Given this list of marker genes Igf1, Rab44, Usp19, Fdx1, Slc8a3, Ide, Ifnk, Fpr2, Hnf1a, Nucks1, Stub1, Ces1d, Prkci, P2rx1, Ptpre, Mecp2, Mbd5, Sdc1, Foxred2, Erbb4, Flna, Tmem38a, Oxt, Ifna14, Ddi2, Slc2a8, Hcfc2, Uprt, P2rx6, Get4, Ly6e, Tnfsf10, Ucp2, Pklr, Bcl2l2, Ncstn, Gabra1, Mir376c, Otop1, Klhl22, Mat2a, Map3k5, P2ry6, Prkcb, Serpina1d, Ankzf1, Txn1, Hdac5, Esrra, Sos1, Nr4a2, Fpr-rs4, Npr2, Oprk1, Fpr-rs7, Mrgpra3, Riok3, Ifna9, Tlr4, Nr4a3, Sec61bl, Chuk, Chmp5, Arhgef2, Apoe, Cd36, Ramp3, Fancb, Fbxo17, Ghr, Sp1, Apc, Orai1, Ehmt2, Prnp, Prss2, Blm, Creb1, Nherf1, Sco1, Htt, Ntrk3, Erlin2, Aplp1, Star, Mir382, Mexis, Gna14, Pcsk1, Pde3b, Ptk2 (PTK2 protein tyrosine kinase 2), Serpina3g, Flt3, Leprot, Selenon, Insig1, Rnf185, Chrng, Irs4, Ncoa2, Ifna6, Slco1b2, Pdk2, Glp2r, Casp7, En1, Obp2a, Stat2, Fgfr3, Usp25, Rps6kb1, Scnn1g, Il1b, Slc5a5, Oprd1, Adamts13, Ncoa5, Braf, Defb25, Ppp2r2a, Gabrb3, Uchl3, Tomm70a, Foxc2, Ube3a, Rangap1, Flot1, Edem1, Adipor2, Crtc3, Pld2, Bace1, A1bg, Calcr, Rplp0 (ribosomal protein lateral stalk subunit P0), Gfral, Panx1, Stt3b, Camk2a, Ces1h, Mup1, Cbs, Ctnnb1, Appl1, Nod2, Parp1, Colec12, Akt3, Zbed3 (NCBI Gene Id 72114), Tns2, Axl, Gcg, Gnao1, Pax4, Htr1a, Ccr7, Gsk3b, Pik3cg, Tmem67, Usp13, Gstm3, Klf16, Ctsk, Cacna1a, Hdac9, Mas1, Dhx15, Hrh4, Slc1a1, Epha8, Prmt5, Prkca, Chrm5, Ezh2, Lyn, Gpx1, Prkcq, Ly6g6e, Ppp3ca, Eef2k, Arc, Pik3r1, Tgfb1, Ly6g, Mir3072, Enpp1, Sox17, Tmem129, Epha2, Myd88, Pak1, Dmtn, Hnrnpd, Srsf5, Cflar, Hcn1, Gnas, Prkcz, Htr4, Adra1b, Mir376b, Gpld1, Epha7, Gjb2, Man1b1, Igfbp5, Insig2, Chrna2, Mef2c, Gm13276, Ptpn22, Mapk8, Slc27a4, Pkd2, Sdf2l1, Hhex, Ciita, Ins2, Nfkb1, Ceacam1, Trim25, Prkn (NCBI Gene Id 50873), Nppc, Kdm1a, Serpina3k, Smpd1, Duox1, Grk2, Cyp11b2, Tmem259, Musk, Tgm2, Ywhag, Adra2a, Fcer1g, Slc7a5, Pdcd4, Cdk2, Hsp90b1, Gnrhr, Trpc3, Kcnb1, Bcar1, Mir369, Cav2, Ccna2, Rab10, Fut7, Homer2, Jak2, Large1, Ubqln1, Rapgef3, Nr1h4, Nck1, Otc, Hadh, Ces1f, Acvr1c, Ly6a (lymphocyte antigen 6 family member A), Prkd1, Ubr2, Afg3l2, Akap6, Ceacam2, Cacybp, Gpihbp1, Jup, Rnls, Aqp8, Cyfip1, Cat, Mir494, Eif2b1, Serpina3i, Mavs, Chrnd, Ces1g, Trem2, Ogg1, Mir27a, Hspa5, Erlin1, Eif2b2, Sik2, Icam1, Rftn1, Nono, Inpp5k, Npm1, Dntt, Hras, Actb, Bdnf, Peli1, Chrna6, App, Sorl1, Ccl19-ps3, Klf15, Mir544, Ptpn2, Derl1, Ntrk1, Ccl19-ps6, Stc1, Snx5, Npc1, Lrp6, Ahcyl1, Asph, Kl, Rela, Tek, Tie1, Larp1, Trdmt1, Stxbp3, Tyms, Diaph1, Fgfr2, Adipor1, Brsk2, Pou4f2, Ddi1, Irs1, Zdhhc7, Grin2a, Fcgr2b, Pde4d, Faf1, Rgs8, Gpd1, Cd9, Ubxn6, Ryr2, Slc26a3 (NCBI Gene Id 80590), Slc24a4, Tomm20, Rgs4, Ephb4, Sdk1, Ror2, Bcl2l1, Insrr, Grb14 (growth factor receptor bound protein 14), Chrm2, Fosl2, Rpl23, Gpr173, Agt, Prkcg, Gnai2, Afg3l1, Rap1b, Ass1, Slc6a3, Ccnd3, Leprotl1, Card9, Gata5, Sin3a, Bmt2, Kcnq1, Srd5a2, Cacna1b, Usp14, Irs3, Slc6a1, Bmp7, Agtr2, Tgfbr3, Igf2, Gnaq, Mfn2, Egfr, Mir409, Myrf, Gabrb2, Ppara (peroxisome proliferator activated receptor alpha), Slurp2, Adtrp, Golph3, Mir487b (NCBI Gene Id 723940), Ly6g2, Lonp1, Ghsr, Crhr1, Dpep1, Map2k1, Gpt, Sorbs2, Fer, Zbtb7b, Slit2, Slc25a33, Nqo1 (NCBI Gene Id 18104), Gnal (NCBI Gene Id 72463), Agrp, Atp2b1, Kcne1, Mir154, Col6a1, H2az1, Lep, Chrna1, Ep300, Epha1, Top2b, Hnmt, Ltk, Crls1 (NCBI Gene Id 75371), Cacng4, Marchf6, Irak3, Flt1, Timp1, Epha5 (NCBI Gene Id 13839), Irf1, Dnajb2, Scnn1b, Trim72, Map3k7, Gldc, Rps6-ps4, Sting1, Mapk1, Ndufs4, Cdk5, Ephb2, Klf2, Eif2ak3, Stxbp4, Tlr9, Capn10, Nos1, Srsf6, Adrm1, Mst1r, Dhfr, Per1, Casq2, Apoc3, Pqbp1, Mylip, Atp2a1, Sirt1, Hlcs, Ppp5c, Cnga3, Mir301, Gad2, Mir423, Drd2, Usf1, Prkaa1, Rnf139, Gck, P2rx3, Umod, Erfe, Insr, Igfbp1, Ifna15, Crtc2, Bglap2, Bglap3, Brip1, Prkaa2 (protein kinase, AMP-activated, alpha 2 catalytic subunit), Hdac2, Ces1e, Ereg, Srsf3, Serpina3c, Afg2b, Retn, Gmps, Ifna7, Htr1b, Bag6, Ubxn2a, Inppl1, Gata6, Syk, Slc39a14, Eif2b5, Gm13272, Sesn2, Ly6h, Aldob, Jak1, Iqgap1, Inava, Ube2j1, Cry1, Akt1, Hadha, Rcn3, Fbxo27, Egln1, Serpina1c, Lrrk2, Carm1, Sgk1, Ces1b, Serpina3h, Uros, Blvra, Psen1, Slc8a1, Lpin3, Nploc4, Dgkq, Trib3, H13, Sel1l2 (NCBI Gene Id 228684), Cdk5r1, Arpc2, Hmgcs1, Cd68, Ly6m, Ngfr, Fbn1, Smpd3, Ubxn10 (UBX domain protein 10), Ifnb1, Mstn, Nt5e, Stat5b, Cyp27b1, Pdk4, Kank1, Foxp3, Trex1, Ptprf, Pmaip1, Prkar1a, Ggh, Six1, Btg1, Uqcrc1, Man1c1, Mtcl2, Selenos, Syvn1, Rhbdd1, Lta4h, Ptpra, Reg3g, Rps6, Gabrg2, Met, Cited1, Htr7, Pitx3, Lrp1 (NCBI Gene Id 16971), Zfp592, Ctsd, Akr1c18, Bsg, Sts, Cyp11b1, Pfkfb1, Rragd, Cad, Daxx, Tmx1, Rab31, Rnf4, Calr (NCBI Gene Id 12317), Mir543, Adcy5, Nfkbiz, Borcs7, Rhoq, Capn1, Fbxo44, Mapk3, Crkl, Nfe2l2, Oxtr, Amfr, Ucp3, Cacna2d1, Col1a1, Trim24, Abat, Mzb1, Grin1, Wdtc1, Stat1, Serpina1e, Eif4ebp2, Canx (NCBI Gene Id 66219), Socs3, Nr5a1, Ptprj, Fgfr1, Tmem38b, Cyc1, Rapgef2, Ntrk2 (neurotrophic tyrosine kinase, receptor, type 2), Nkx6-1, Ifnz, Reg3b, Ces1c, Ly6f, Ubac2, Pld1, Brca1, Adora2a (adenosine A2a receptor), Baiap2, Thbd, Gm13283, Itgb1, Abcc9, Sort1, Rbp4 (retinol binding protein 4, plasma), Ezr, Ifna5, Srebf2, Adm, Serpina1b, Xbp1, Itpr2, Irak1, Raet1d, Rigi, Mmp9, Rnft2, Gna15, Alad, Lgmn, Crhbp, Trarg1, Castor2, Ace, Epha6, Fam114a1, Scn11a, Pde1b, Casr (NCBI Gene Id 12374), Inhbb, Adrb2, Hnf4a, Chek1, P2ry12, Pdpk1, Zcchc3, Ubqln2, Htr6, Fbxw8, Ubxn1, Raf1, Mtor, Ufl1, Foxo1, Slc6a4, Dlg4, Ldlr, Mul1, Ly6g6d, Duox2, Anxa7, Fpr-rs6, Itpr3, Zfp36l1, Cpt1a, Ddr1, Appl2, Ncam1, Slc2a1, Ppp1r9b, Vps13c, Klf4, Nefl, Serpina1a, Sesn3, Drd4, Tnfsf4, Eif6, Prkcd, Comt, Itga2, Trpv4, Bloc1s6, Bglap, Stambpl1, Grb7, Adcy6, Ern1, Pip4k2b, Kit, Lhcgr, Mmp19, Hcn3, Ticam1 (NCBI Gene Id 224899), Faf2, Mrgpra1, Ctnna1, Galp, Rab8a, Prmt1 (protein arginine N-methyltransferase 1, NCBI Gene Id 80681), Smarcc1, Hdac6, Plcd1, Htr2b, Mapk14, Cxcl2, Rftn2, Src, Aup1, Svip, Sp7, Dhx36, Nanog, Ada, Dnajb12, Ghrhr, Tnf, Itga4, Cib2, Fkbp1a, Scnn1a, Pparg, Lars1, Chrm4, Map1b, Epha10, Gm13271, Akap7, Prkaca, Kcnc1, Lpin2, C5ar1, Gstm6, Cdh13, Rapgef1, Nlrp1a, Stk11, Ache, Hcn2, Spidr (NCBI Gene Id 77584), Bcar3, Eprs1, Cela2a, Ccdc47, Drd3, Dbh, Derl3, Osbpl8, Hes1, Slc1a2, Tmub1, Fbp1, Mia3, Mtarc2, Cdo1, Gm13275, Kbtbd2, Ifna2, Hnrnpk, Tyro3, Ephb3, Fbxo6, Rad51 (RAD51 recombinase), Chrnb4, Tlr2, Ankrd26, Tuba1a, Slc2a4, Epm2aip1, Gper1, Ces1a, Epha3, Slc26a6, Gata1, Mir143, Flt4, Th, Il10 (interleukin 10), Pde12, Sox9, Irs2, Ptger1, Mir667, Tdo2 (tryptophan 2,3-dioxygenase), Rbm4, Dhx9, Cnr1, Tshr, Alk, Ranbp2, Sesn1, Max, Fos, Gm13277, Lrrc25, Blvrb, Atp1a3, Phb1, Khk, Sec61b, Cul3, Clgn, Ikbkb, Cracr2a, Erbb2, Kat7, Fcsk, Cps1, Grm2, Gdf15, Gh, Adgrl3, Drd5 (NCBI Gene Id 13492), Ripk2, Mup3, Tpr, Adcy8, Ren1, Grb10, Nfkbia, Epha4, Birc2, Mapkap1, Psmc6, Aqp11, Eif2a, Grb2, Pdgfrb, Ncl, Gria2, Htr2a, Ifna4, P2rx5, Ifna13 (interferon alpha 13), Alpl, Stat3, Hsf1, Slc9a1, Xlr4b, Ager, Epg5, Crem, Socs2, Pid1 (NCBI Gene Id 98496), Gstp1, Tor1a, Echdc3, Cdkn1b, Ddx21, Umodl1, Ccl19-ps4, Grxcr1, Ptprv, Palm, Nr3c2, Sfrp1, Hdac8, Ros1, Plcg2, Recql5, Lncbate10, Lypd1, Edem3, Ifih1, Rap1gds1, Rap1a, Atrx, Atxn3, C1qtnf12, Vim, Casp1 (NCBI Gene Id 12362), Hmga1, Lpl, Nsmce3, Tbc1d4, Gna11 (guanine nucleotide binding protein, alpha 11), Rnf103 (ring finger protein 103), Tsc2, Jag1, Fgfr4, Smad3, Pde2a, Setd2, Ptgs2, Pnpt1, Cacna1s, Lipa, Gclc, Cybb, Pik3ca, Trp53, Gnb5, Errfi1, Ssh1, Hcn4, Chrna7, F7, Fadd (Fas associated via death domain), Eif2b3, Trpc1, Nagk, Gucy1b1, Cdk1, Akap9, Bche, Eif2s1, Trpm2, Ly6c2, Ryr1, Lmnb1, Edn1, Pcna, Gja1, Plcb1, Reg1, Ubxn8, Dnajb9, Agap2, Srebf1, Gdf10, Ifnab, Tlr6, Cntnap2, Rock1, Pomc, Snx6, Mir23a, Ccl19, Rb1, Mir150, Ptk2b, Nlrp3, Kcnj8, Gstm7, Dnai1, Lpin1, Nscme3l, Cgas, Abcc1 (NCBI Gene Id 94110), Ins1, Mir539, Mir124a-1hg, Atp2b4, Slc30a10, Myo5a, Itgb2, Ddx1, Got1, Edem2, Eif4ebp1, Rgs10, Erlec1, Dennd4c, Ifng (NCBI Gene Id 15978), Sel1l, Rtf2, Gcnt1, Rnf5, Jak3, Srsf9, Jkamp, Wfs1 (wolframin ER transmembrane glycoprotein), Hrh1, P2rx4, Ndel1, Vcam1, Derl2, Itgav, Ubr1 (NCBI Gene Id 99008), Egr2, Agtrap, Chrna3, Vwa2, Trpv1, Pgr, Ly6i, Tsc1, Vps35, Atp5f1a, Fyn, Crebbp, Ext1, Ddr2, Htr3a, Agtr1b, Notch1, Abcc2 (ATP-binding cassette, sub-family member 2), Lrp5, Ednra, Vcp, Hpca, Slc3a2, Gpr82, Tacr3, Ly6g6g, Nrros, Wnt1, Nudc, Foxo3, Tnfrsf11a, Asic1, Rrm2b, Csf1r, Itpr1, Pck1, Nccrp1, Ifna12, Ccl2, Chrnb3, Man1a, Ascl1, Stim1, Kcnq3, Mgarp, Kat2b, Sh2b2, Cyp1b1, Ube2g2, Kdr, Abcb1a, Pax6, Vamp2, Pygm, Crhr2, Stat4, Ryr3, Mup2 (NCBI Gene Id 17841), Ptafr, Tlr3, Gpr21, Rock2, Reg3d, Cfl1, Mmp2, Egr1, Ube4a, Sgta, Sirt6 (NCBI Gene Id 72769), Timeless, Gabrb1, Crh, Ralb, Zfp106, Serpina3f, Slc1a3, Cyp11a1, Penk, Socs7, Mup4, Trpm4, Nod1, Thbs1, Shc1, Socs1, Aldh3a1 (NCBI Gene Id 11670), Rbx1, Gfer, Hsd11b2, Snca, Pxn, Phex, Homer1, Pkm, Rgs2, Npy1r, Oaz1, Adora1, Btg2 (BTG anti-proliferation factor 2), Pik3r3, Htr2c, Mir208b, Fpr-rs3, C1qtnf9, Rnf145, Socs5, Ufd1, Gria1, Stat6, Tmub2, Gcgr, Casp6, Irf3 (NCBI Gene Id 54131), Folr1, Areg, Rac1, Uso1 (USO1 vesicle docking factor), Mir666, Crtc1, Slc18a2, Mdm2, Gip, Gclm (NCBI Gene Id 99692), Chrne, Pdxp, Hsp90aa1, Yod1, P2ry1, Ecpas, Amigo1, Glp1r, Nucb2, Zc3hav1, Crk, Rgs9, Mup11, mt-Cytb, Ifna1, Cp, Reg2 (regenerating islet-derived 2), Gpam, Mir24-2 (NCBI Gene Id 723960), Prkdc, Lynx1 (NCBI Gene Id 23936), Anxa5, Shmt1, Inhba, Man1a2, Actn2, Erbin (Erbb2 interacting protein), Gprin3, Fosl1, Tyr, Cpeb2, Ptpn1, Igf1r, P2rx2, Cftr, Scap, Elavl4, Gkap1, Stat5a, Irf5, C2cd5 (C2 calcium-dependent domain containing 5), Mc4r, Bckdhb, Cav1, Mir1897, Prkce, Cartpt, Trim13, Rnf121, Csrp3, Grm5, Adora2b (adenosine A2b receptor), Grin2d, Herpud1, Chrnb2, Kcnj11, Cpeb1, Cdh1, Oprm1, Car2, Ppp1r1b, Cda, Ifna16, Rab13, Ube2j2, Cd2ap, Traf2, Pip4k2c, Ptpn11, Mir496a, Trim41 (tripartite motif-containing 41), Ephb1, Tlr7, Reg3a, Fbxo2, Prlh, Os9, Rnft1, Htr3b, Calr4, Mir495, Folr2, Pdgfra, Hrh3, Mertk, BC004004, Myo1c, Marcks, Stc2, Gm527, Ang2, Ddx11, Pck2, Cxcr4, Agxt, Pcsk9, Sell, Ccl19-ps1 (C-C motif chemokine ligand 19, pseudogene 1), mt-Nd6, Chrnb1, Phip, Ubxn4, Pip4k2a, Slc27a1, Foxo4, Hprt1, Aanat, Cacnb1, Tyk2, Dnajc10, Tnfaip3, Ogt, Chrm1, Agtr1a, Taar1, Fkbp5, Ldoc1, Serpina3n, Gsk3a, Pde3a, Tspo, Chrna4, Ahsg, Adss2, Itgb3, Atp2a2, Serpina3m, Aqp1, Csk (c-src tyrosine kinase), Cd81, Mtarc1, Hmgcs2, Ifitm5, Pdx1, Mtr, Cul7, Scly, Mir22 (NCBI Gene Id 387141), Cry2 (NCBI Gene Id 99248), Ret, Xlr4a, Nr4a1, Ncoa1, Syap1, Akt2, Wnt10b, Ly6c1, Mir654, Dnmt3a, Gnai3, Adipoq, P2rx7, Kynu, Kdm6a, Sos2, Ccl19-ps5, Kcnc2, Mir377, Gatm, St8sia2, Rps6kb2, Tmbim6, Psca, Ednrb, Ahr, Aifm1, Serpina12, Col3a1, Castor1, Il18, Opa1, Camp, Sorbs1, Rptor, Myc, Mup5, Atf1, Drd1, Tcf12, Gstm5, Gk (NCBI Gene Id 319419), Chrm3 (NCBI Gene Id 12671), Shoc2 (Shoc2, leucine rich repeat scaffold protein), Mir376a, Ifne (NCBI Gene Id 230405), Ifna11, Meak7, Ggcx, Casp3, Grin3b (NCBI Gene Id 170483), Pik3r2, Eif2b4, Pten, Dag1, Ffar3, Fosb, Dnm2, Bcap31, Chrna5, Ube4b (ubiquitination factor E4B), Vgf, Sgcb, Dtnbp1, Calr3, Rarres2, here is a description of the gene set: species: Mus musculus Mouse Gene Set: GOBP_RESPONSE_TO_NITROGEN_COMPOUND Any process that results in a change in state or activity of a cell or an organism (in terms of movement, secretion, enzyme production, gene expression, etc.) as a result of a nitrogen compound stimulus.